The following is a description of a gene set: Reactome Pathway: Signaling by TGFBR3 TGFBR3, also known as betaglycan, is a member of the proteoglycan family and plays a key role in regulating TGF-beta receptor-mediated signaling as well as TGF-beta-independent signaling (Wiater et al.,2003, Andres et al., 1992). TGFBR3 is expressed in abundance in normal cells and is known to be down-regulated in multiple cancers due to its function as a tumor suppressor (Zhang et al.,2020, Fang et al.,2020, Cook et al.,2019). TGFBR3 is a transmembrane protein but lacks kinase activity in its cytoplasmic domain (López-Casillas et al.,1991). TGFBR3 primarily works as a co-receptor for different signaling pathways and can either facilitate or inhibit them (Wiater et al.,2003, Andres et al., 1992, Esparza-Lopez et al., 2001). TGFBR3 binds to TGF-beta ligands, facilitates their presentation to the TGFBR2 receptor, and helps in complex formation between TGFBR2 and TGFBR1. TGFBR3 also facilitates FGF:FGFR receptor complex stability and functions in FGFR1-mediated signaling as a co-receptor. TGBFR3 regulates signaling by other TGF-beta family members, including BMP2/7 and Activin (Wiater et al.,2003). Thus, TGFBR3 is involved in normal cell signaling and plays an important role in cancer, inflammatory diseases, and Alzheimer's. part of: Signaling by TGFB family members studied in species Homo sapiens, and this is the list of marker genes: KLF16, AGO3, MYOD1, TGFBR3, TNRC6B, APH1B, ARRB1, EP300, TGFBR1, MIRLET7A1, GIPC1, SMAD4, AGO1, TGFB1, APH1A, AGO4, AGO2, RARA, SP1, TCF3, PSEN2, TCF12, PSENEN, ACVR2A, ARRB2, TIMP1, MOV10, NCSTN (nicastrin), MMP14, MIR27B, MMP16, MYF5, TCF4, INHBA, MIR23B, HELLS, TGFBR2, TIMP2, SMAD3, RXRA, TNRC6A, PSEN1, FGF2, TNRC6C, MYOG, MYCN, TGFB2, INHA, MYF6